The following is a description of a gene set: Genes predicted to be targets of miRBase v22 microRNA mmu_miR_290a_5p, mmu_miR_293_5p in miRDB v6.0 with MirTarget v4 prediction scores > 80 (high confidence targets). from publication Chen Y, Wang X (PMID 31504780) Mouse Gene Set: MIR_290A_5P_MIR_293_5P studied in species Mus musculus, and this is the list of marker genes: Ctcfl, Stxbp3, Sh3bgrl2, F11r, Srsf3, Rps6kb1, Mycs, Csgalnact2 (NCBI Gene Id 78752), Tet1, Pcdh8, Wdr44, Ccr2, Zfp719, Dsp, 1700066M21Rik, Hbq1a (hemoglobin, theta 1A), Gxylt1 (NCBI Gene Id 382997), Zfp446, Mapre1, Cep72 (centrosomal protein 72), Spib, Adipoq, Clock, Nudt11, Zfp950, Btg3, Celf1, Edn3, Mbnl1, Scn7a, Coa3, Zfp644, Tmem50b, Atp6v0a4, Cadm2, Ccl2, Mylk4, Col4a2, Rc3h2, Zfp868, Nup35, Cbln3, Atg4d, Arfgap2 (ADP-ribosylation factor GTPase activating protein 2), Crispld2, Becn1, Dmrta1, Setd1b, Shbg, Map3k1, Csnk1a1, Pcdhb4, Opn5, Hp1bp3, Slc5a3, H2-Ob, Tpbg, Pank3, Hdac8, Actbl2, Cnot6l, Anks1b, Cdk12, Ccnyl1, Nbr1 (NCBI Gene Id 17966), D5Ertd579e, Vcam1, Ark2n, Slc35e1, Uty, Sptbn1, Rcan2, Rexo1 (REX1, RNA exonuclease 1), Tm4sf1, Mr1, Pramel27, Pcmtd1, Dab1, Sgip1, Nkx2-2, Med7, Ppp4r3a, Arhgap15, Cfl2, Mapk8, Sec24a, Zkscan8, Afdn, AI597479, Rer1, Zfp113, Sfmbt2, Zbtb33, Akap13, Trp63, Zfp1005, Pptc7, Plagl1, Svbp, Hbq1b, Eef2k, Rhpn2, Ric3, Rpl32l, Uspl1, Sox2, Zfp729b, Tmem170b, Extl3, Cd40, Arrdc3, Gfral, Nexmif, Dock2